The following is a description of a gene set: Human Gene Set: GOBP_MORPHOGENESIS_OF_AN_ENDOTHELIUM The process in which the anatomical structure of an endothelium is generated and organized. Endothelium refers to the layer of cells lining blood vessels, lymphatics, the heart, and serous cavities, and is derived from bone marrow or mesoderm. Corneal endothelium is a special case, derived from neural crest cells. species: Homo sapiens, and this is the list of marker genes: RHOB, LCN2, DLL4, ADAMTS12, RHOA, MIR21, FOXP1, CXCL10, PRKD2, ACVRL1, CCM2, STARD13, ITGAX, CTNNB1, FGF1, RBPJ, CSNK2B, BSG